Given this list of marker genes Arfrp1, Rock2, Pitx2, Klf4 (NCBI Gene Id 269540), Nipbl, Nr4a3, Reck, Scrib, Luzp1, Alx1, Rbpms2, Sox2, Sobp, Mapk1, Hoxa5, Sox9, Shank3, Paf1, Tal1, Twist2, Kcnq1, Fbn1, Aff3, Sparc, Nat8f3, Rpl38, Rbpj, Efemp1, Lamb3, Hoxa7, Map3k20, Cc2d2a, Mapk7, Traf3ip1, Grem1, Grxcr1, Mbnl1, Syf2, Llgl2, Ets2, Mthfd1, Ift52, Hoxd3, Rdh10, Prkacb, Myadm, Fzd3, Erf, Rnf2 (NCBI Gene Id 98537), Fzd7, Hyal1, Fzd5, Ofd1, Ece1 (endothelin converting enzyme 1), Kat2a, Itgb1, Tead2, Hspg2, Arhgap35, En1, Prkar1a, Rps7, Nkx2-5, Men1, Abl1, Smad4, Bmp8b, Foxh1, Col11a1, Acd, Hhex, Hnf1a, Ctnnb1 (catenin beta 1), Phldb2, Etv2, Fbn2, Smarca1, Gdf5, Tifab, Ugdh, Mmp15, Pax3, Itgb4, Tgfb1i1, Cplane1 (ciliogenesis and planar polarity effector 1), Clic5, Chrna9, Apela, Clrn2, Bcr, Rest, Coq7, Lrp5, Tcf21, Bmp5, Lrp6, Kcnq4 (potassium voltage-gated channel, subfamily Q, member 4), Gpi1, Pals1, 2610005L07Rik, Lhfpl5, Sp8, Sp1, Irx2, Esx1, Hoxa3, Ush1c, Trp63, Grhl2, Macroh2a1 (NCBI Gene Id 26914), Nf2, Acvr2b, Dync2i1, Sox7, Wnt2b, Ski, Tshr, Axin1, Prox1, Fzd2, Lama5, Lmx1b, Scx, Lef1, Hoxa9, Foxi1, Ptk7, Tbx15, Hipk1, Wnt7b, Foxe1, Grxcr2, Mapk3, Zeb2, Spint1, Spry2, Irx3, Clrn1, Lrp4, Tbx19, Hoxc10, Itga3, Mmp16, Col5a1, Foxc2, Pou4f3, Nherf1, Rara, Kdm6b, Stk4, Hes3, Flvcr1, Gas1, Hoxa4, Osr2, Cer1, Ift172, Aldh1a2, Ovol2, Lrp2, C2cd3, Fgfr1, Naglu, Pdx1, Kif16b, Hsbp1, Tbx3, Foxf2, Ttbk2, Nsd1, Pdgfra, Nat8f1 (NCBI Gene Id 66116), Tctn1, Dicer1, Alx3, B9d1, Pcgf2, Ror2, Hoxd10, Kdm2b, Hoxb8, Myc, Fuz, Rala, Med1, Myo3b, Tasor, Ndst1, Ift140 (intraflagellar transport 140), Fn1, Kif3a, Acvr2a, Edn1, Bmp7, Txnrd1, Cdk20, Gbx2, Sulf1, Gata6, Hoxc11, Deaf1 (DEAF1, transcription factor), Nectin3, Hpn, Wnt5a, Map3k7, Lama3, Grem2, Dlx6, Prkaca, Stox1, Pkd2, Rtf1, Ift57, Tmed2, Osr1, Tgfb3, Hoxd13, Fgf9, Ret, Arl13b, Shroom3, Epha2, Ankrd24, Pls1, Myo3a, Dvl2, Macf1, Notch2, Mir216b, Rarg, Folr1, Chrd, Gsc, Dab2, Hectd1, Cobl, Wnt3a, Tfap2a, Wnt9b, Map2k1, Wdr83, Traf6, Cfc1, Dnaaf1, Tprn, Amot, Prrx1, Dkk1, Tgfb2, Zfp568, Gja5, Strc, Dusp2, Kdm2a, Ahdc1, Dlc1, Hoxb7, Tead1, Megf8, Hoxa11, Nectin1, Zic1, Taf10, Crb2, Jag2, Ptprq, Atp8a2, Zeb1, Tgif1, Zfp281, Hipk2, Setd2, Cdon, Sec24b, Gna12, Srf, Myo15a, Slc39a1, Mir96, Pou5f1, Mafb, Mixl1, Tcap, St14, Zic3, Myo7a, Sox8, Nckap1, Prickle1, Mthfd1l, Tbx4, Kdf1, Hira, Slitrk6, Ext2, Cacna1c, Mesp2, Dusp5, Ephb2, Brpf1, Ush1g, Eif4a3, Aplnr, Bmp4, Fgf8, Tcf3, Hmx2, T2, Hoxd12, Sod1, Itgav, Gdnf, Hand2, Sufu, Stil, Cfl1, Lbx2, Cecr2, Ttc39c, Fbxw4, Rab23 (RAB23, member RAS oncogene family), Ncoa3, Lmbr1, Cited2 (NCBI Gene Id 17684), Hoxb6, Kif20b, Hmx3, Apln, Hoxd11, Tbx1, Sfrp1, Eya1, Ythdf2, Eomes, Map2k5, Rac1, Rack1, Rspo3, Mbp, Wnt3, Frs2, Cripto, Pcdh8, Gdf7, Med12, Ccdc40 (NCBI Gene Id 277022), Tgif2, Rgma, Dld, Mir217, Sall1, Bmpr1a, Wnt1, Apoa1, Hnf4a, Hlx, Vangl2, Lefty1, Il1rn, Poglut1, Ccdc103, Runx2, Ptch1, Mib1, Stk3, Pbx1, Lhx2, Gja1, Mef2c, Sall4, Gfi1, Otx2, Dag1, Hoxb4, Hoxb1, Myf5, Gata4, Frzb, Hoxd9, Triobp, Mmp14, Twist1 (twist basic helix-loop-helix transcription factor 1), Dscaml1 (DS cell adhesion molecule like 1), Nodal, Id2, Itga5, Mmp8, Prkra, Mdfi, Tmie, T, Armc5, Tecta, Foxn4, Zbtb17, Snai1, Tnrc6c, Gatad2a, Cyp26b1, Trim71, Lnpk, Otop1, Gli2, Col6a1, Slc44a4, Adipoq, Insig2, Whrn, Hoxb2, Hoxd4, Hesx1, Asb2, Aldh1a3, Mthfr (NCBI Gene Id 17769), Wnt11, Lbx1, Chst11, Eif4a3l1, Fzd6, Mfap5, Igf2, Tcf7l2, Dlx5, Smo, Col8a1, Il10, Zic5, Ar, Alx4, Crabp2, Insig1, Brd2, Bcl10, Hif1a, Mesp1, Clasp2, Mmp9, Tlx2, Twsg1, Frem2, Opa1, Grb2, Bmpr2, Flrt3, Tshz1, Nat8f2, Six4, Lmo4, Specc1l, Slc39a12, Bpnt2 (3'(2'), 5'-bisphosphate nucleotidase 2), Ybx1, Nat8f5, Sox17, Vcam1, Dnajb6, Eya4, Efna1, Gjb6, Prrx2, Tulp3, Tgfbr1, Hoxc9 (homeobox C9), Gata3, Th, Leo1, Sema4c, Htt, Sdc4, Atp2b2, Phactr4, Six1, Mecom, Gli3, Gnaq, Cul3, Vasp, Notch1, Vegfc, Msx2, Msx3, Hes5, Rnf207, Foxc1, Psen1, Tgfb1, Ecsit, Wnt4, Enpp1, Tbc1d32, Sp3, Chrna10, Hdac1, Tsc1, Hoxb3, Irx1, Cdc73, Gcm1, Fgfr2, Hmga2, Wls, Smad1, Hoxa13, Rpgrip1l, Col2a1, Gata2, Sp9, Pou2f1, Clasp1, Ccdc39, Wnt6, Irx5, Hoxc4, Bbs4, Pbx2, Pitx1, Foxg1, Smad3, AI597479, Gnas, Bcl2l11, Esrrb, Mab21l2, Tbx18, Six3, Elf5, Dync2h1, Atoh1, Cdh23, Ihh, Wdpcp, Rps6, Lats1, Ccn1, Dvl1, Tbx6, Tnfaip3, Mmp2, Pfn1 (NCBI Gene Id 18643), Col5a2, Bloc1s5, Neurog1, Tbx20, Grhl3, Fras1, Nkx3-2, Fgf10, Sox11, Stra6, Col4a2 (collagen, type IV, alpha 2), Ednra, Gdf3, Ipmk, Rspo2, Slc39a3, Casp8, Setdb2, Ift122, Mical2, Wnt9a, Intu, Itgb3, Enah, Socs3, Nat8, Lias, Dusp4, Dll1, Htr2b, Otx1, Tmem231, Mks1, Dusp1, Sos1, Dlx1as, Plpp3, Pou3f4, Nr0b1, Plxnb2, Phldb1, Mycn, Itga4, Tmem107, Pax8, Gjb5, Adm, Satb2, Itga2, Glmn, Wnk1, Noto, Dll4, Hdac2, Tbx5, Pax5, Fgf4, Psen2, Msx1, Zic2, Nanog, Trp53, Brd3, Atoh8, Hoxb9, Ric8a, Grsf1, Ctr9 (NCBI Gene Id 22083), Lats2, Myo6, Ripor2, Itga8, Wnt5b, Ryr2, Col12a1, Neurod1, Pcdh15, Myh9, Abl2, Hoxa1, Spint2, Lhx1, Kdm6a, Zfp36l1, Lrig3, Smad2, Wdr19, Gli1, Atp6v1b1, Msgn1, Hs2st1, Dvl3, Acvr1, Tsc2, Dlx2, Hnf1b, Abr, Pdzd7, Sfrp2, Gpc3, Casp3, Mosmo, Tgfbr2, Vax2, Eif4a3l2, Rarb, Foxl2, Hoxa2, Tbx2, Nup50, Wnt7a, Hand1, Arid1a, Wnt2, Ppp1r35, Pax6, Yap1, Chd7, Inhba, Vtn, Aldh1a1, Mir216a, Lrig1, Rbp4, Foxf1, Mfap2, Bmi1, Foxp4, Lmbrd1, Exoc4, Trim28, Cep290, Ntn1 (netrin 1), Pofut2, Shh, Flt1, Hoxb5, Fgf3, Pds5a, Nog, Dact1, Ift88, Celsr1, Epb41l5, Hoxa10, Supt20, Foxa2, Shox2, Ldb1, Dlg1, Ncoa1 (NCBI Gene Id 17977), Hes1, Zbtb16, Bax, Rock1, Nphp3, Cluap1, Cryaa, Tenm4, Ext1, Cdkn1c, Eng, Apaf1, Tcf7, Six2, Cthrc1, Smarca4, Asxl2, Pax2, Rbm14, here is a description of the gene set: studied in species Mus musculus Mouse Gene Set: GOBP_EMBRYONIC_MORPHOGENESIS The process in which anatomical structures are generated and organized during the embryonic phase. The embryonic phase begins with zygote formation. The end of the embryonic phase is organism-specific. For example, it would be at birth for mammals, larval hatching for insects and seed dormancy in plants.